The following is a description of a gene set: studied in species Homo sapiens Human Gene Set: GOCC_GAMMA_TUBULIN_COMPLEX A multiprotein complex composed of gamma-tubulin and other non-tubulin proteins. Gamma-tubulin complexes are localized to microtubule organizing centers, and play an important role in the nucleation of microtubules. The number and complexity of non-tubulin proteins associated with these complexes varies between species., and this is the list of marker genes: TOPORS, CENPJ, CDK5RAP2, MARK4, TUBGCP4, TUBGCP3, MZT2B, BLOC1S2, PDE4B, TUBG1, MZT2A, TUBGCP6, BRCA1, TUBG2, TUBGCP5, NME7, MZT1, TUBGCP2